The following is a description of a gene set: The directed movement of a L-lysine into, out of or within a cell, or between cells, by means of some agent such as a transporter or pore. Mouse Gene Set: GOBP_L_LYSINE_TRANSPORT studied in species Mus musculus, and this is the list of marker genes: Slc66a1, Slc7a1, Slc7a3, Agt, Slc25a15, Slc25a2, Slc25a29, Slc7a6